The following is a description of a gene set: studied in species Homo sapiens Human Gene Set: HP_MALIGNANT_GENITOURINARY_TRACT_TUMOR The presence of a malignant neoplasm of the genital system. Malignant genitourinary tract tumor, and this is the list of marker genes: RPS15A, RPL35A, RPS10, HEATR3, RPS17, RPL11, RPL8, MSH6, RPL18, EPCAM, RPL9 (NCBI Gene Id 6133), RPL15, RPS24, BLM, MLH1, RPL26, PMS2, KRAS, TGFBR2, RPS19, MSH2, RPL35 (NCBI Gene Id 92393), RPS26, RPL27, RPL31, RPS29, RPS28, PMS1, RPL5, PIK3CA, TSR2, RPS7, ADA2, RPS20, GATA1, RPS27